Given this list of marker genes Trim11, Ephb1, Tgfb1i1, Msx2, Stat5b, Eid2b, Acvrl1, Mfn2, Lilrb4b, Nr2e1, Sox10, Fgf9, S1pr3, Id1, Hoxa9, Ldb1 (LIM domain binding 1), Nmrk2, Lilrb4a, Cdc73, Plxna3, Mir133a-1, Foxa2, Cxcl14, Clec4g, Thy1 (thymus cell antigen 1, theta), Wnt4, Trpv1, Mir125a, Bmal1, Rap1gap, Runx1, Dpf2, Tgfb2, Mir669a-4, Hey1, Zbtb7b, Prmt5, Npr2, Nodal, Gdf11, Elf5, Vhl, Clec2i, Cdkn2a, Xbp1 (NCBI Gene Id 52219), Tbx1, Shh, Meis2, Disp3 (NCBI Gene Id 631463), Notch1, Slc6a4, Grem1, Casz1, Bcl7a, Six4, Trib1, Kdm1a, Rgs4, Ankrd26 (ankyrin repeat domain 26), Pglyrp2, Rest, Extl3, Asxl1, Pbx1, Myc, Il4, Mafb, Il17rd, Kifap3, Ntn1, Trio, Igf1, Ankrd2 (NCBI Gene Id 56642), Efnb3, Map2, Nkx3-2, Fgfr1, Pcid2, Axin1, Pramel1, Kat8, Flt3, Rc3h1, Ccnk, Six3, Med28, Ifrd1, Fas, Mir23a (microRNA 23a), Ihh, Mir30c-2, Fezf2, Lag3, Ntrk3, Trim72, Trpc5, Stat3, Fndc3b, Foxg1, Trak2, Bmp2, Abcc8, Sinhcaf, Nf2 (neurofibromin 2), Ptprs, Nox1, Shb, Inpp5d, Men1, Tgfb1, Zc3h12a, Tmem178, Gorasp1, Pira12, E2f1, Notch3, Ccn4, Fstl4, Rtn4r, Hoxb8, Sfrp1, Gdf5, Cit, Trim46, Clec2g, Ptk2, Mbnl3 (muscleblind like splicing factor 3), Ezh2, Smad3, Fbxw7, Pias3, Ulk2, Sema4f, Calr, Skic8, Trp53inp1, Nfatc4, Rbm10, Ccdc85b, Zfp35, Erbb2, Gpr55, Vegfa, Vasn, Paf1, Tunar, Zfp36l2, Dll1, Ccl3, Mir669a-9 (NCBI Gene Id 100526491), Eif4enif1, Ctdp1, Rara, Smad1, Bdnf, Il17d, Rgma, Dact3, Fstl3, Ctr9, Adcyap1, Cdk12, Epha7, Dmd, Hbp1, Nr1d1, Hspa9, Wnt7a, Bmp4, Foxp1, Foxj2, Ptch1, Mir669a-10, Tmem64, Rufy3, Nfkbia, Nme1, Smad6, Pax6, Daxx, Nbn, Hook3, Cd44, Dicer1, Ucma, Zfp36, Tspo, Pawr, Reg3a, Erfe, Spart, Fgf13, Cfl1, Ppara, Pira1, Notch4, Foxp4, Spdef, Lbx1, Rbm15, Nfatc2, Sema3g, Mir669a-1, Pik3r1, Tnn, Ptk2b, Igf2 (insulin-like growth factor 2), Gpr171, Yy1, Actl6b, Spred3, Cdkl3, Frs2, Hopx, Adipor1, Noct, Il2, Sox3, Mmp11, Spred2, Snai1, Insig1, Cntf (NCBI Gene Id 12803), Itgav, Ulk1, Appl2, App, Wnt3a, Pou4f2, Trpm4, Slc4a2, Ccl21b, Flcn, Tcf7l2, Rflnb, Mir7-1, Foxa1, Pparg, Suz12, Daam2, Id4, D130043K22Rik, Klf13, Nfatc1, Dtx1, Ctnna1, Kdm4a, Dlk1, Eif2ak4, Rtn4, Nepro, Tcf15, Sox8, Irf1, Lsm1, Nppc (natriuretic peptide type C), Tnfaip6, Prl2c2, Rnf6, Lbh, Tmem131l, Lrp4, Lrrc17, Smarcd1, Kras, Mir217, Tmem176a, Ccn3, Ldlr, Ipo7, Runx1t1, Foxp3, Sall1, Zfp750, Smad4, Chadl, Pcm1, Gper1, Fbn1, Ryk, Tmem53 (transmembrane protein 53), Pi16, Sema3f, Esrrb, Lhx2, Smarcc1, Mkx, Dleu2, Ldlrad4, Zfhx3 (NCBI Gene Id 68160), Trp53, Meis1, Hey2, Ranbp3l, Rbpj, Ceacam1, Tmem182, Vegfc, Ubash3b, Mir338, Fbxo11, Col5a1, Tnpo2, Hnrnpu, Bbs12, Ccl11, Socs1, Dnmt1, Rpl3l, Gfi1 (growth factor independent 1 transcription repressor), Wnt9a, Lmx1a, Draxin, Ifnb1, Apcs, Vsx2, Spry2, Phox2b, Bex1, Sirt2, Nkx2-1, Zfpm1, Cdk13, Sort1, Itgb3, Sorl1, Wnt1, Sostdc1, B2m, Gdi1, Sox21, Twist2, Trim6, Srsf6, Btg2, Adamts7, Hes5, Mir30c-1, Sox4, Zfp36l1, Fuz, Bcl6 (NCBI Gene Id 12053), Bicral, Prdm16, Shoc2, Six2, Irgm1, Glis1, Bambi, Slc7a10, Bmpr1a, Tmem98, Clec2d (NCBI Gene Id 93694), Dlx2, Pth, Tlx3, Rorb, Wnt3, Anxa1, Slit2, Tmem176b, Oog2, Arhgap4, Il1b, Msx1, Gsk3a, Wnt5a, Rgs2, Mir137, Atf5, Tsc22d1, Gpr137, Actb, Foxo3, Cul4a, Nrp1, Adgrv1, C1qc, Tnf, Mbp, Akirin1, Tsc2, Ddx6, Rbpms2, Pkp2, Lingo1, Axin2, Spsb3, Rhoa, Dip2b, Fgfr3, Sox9, Stat1 (signal transducer and activator of transcription 1), Mir669a-2, Mir448, Plpp7, Cftr, Foxo4, Mixl1, Ncor2, Hmga2, Tcf23, Cav3, Hoxa5, F2, Fgf23, Nog, Ostn, Cib1, Hes1, Wnt7b, Tomm70a (NCBI Gene Id 70049), Fbxo7, Spinkl, Nf1, Areg, Cd74, Sox11, Ccr5, Ereg, Ascl2, Ybx1, Arhgef2, Nkx6-2, Nfatc3, Mycn, Ankrd17 (NCBI Gene Id 81702), Ahr, Mir669a-8, Ccnd1, Nrarp, Foxe3, Id2, Sema6d (sema domain, transmembrane domain (TM), and cytoplasmic domain, (semaphorin) 6D), Skil, Eif4e, Thoc5, Prdx2, Cdh1, Cav1, Tlx2, Mir669a-3, Bmpr2, Sema5a, Nbr1, Ephb2, Pinc, Snai2, Mir669a-5, Wee2, Zbtb46, Aspm, Smo, Hmgb3, Usf3, Itpkb, Efemp1, Gps2, Crp, Vax1, Mapk1, Fgl2, Gabpa, Wwtr1, Cartpt (CART prepropeptide), Mib1, Gli3, Itgb1, Dpysl5, Hpn (hepsin), Dab1, Fmr1, Loxl3, Cers2, Hspb1, Dll3, Socs5, Bcl7b, Dkk1, Ss18, Riox1, Olig2, Zhx2, Pak1, Yap1, Tjp2, Sirt1, Grb14, Chrd, Dab2ip, Gli2, Sema4d, Pglyrp1, Ltbp3, Cntn4, Rag2, Bicra, Tlcd3b, Actr3 (ARP3 actin-related protein 3), Zfp418, Zfpm2, Cbfb, Kctd11, Cited1, Ptpn11, Prox1, Cdk5rap2, Sema6c, Ifng, Nkx2-2, Adipoq, Hoxa7, Col5a2, Il4ra, Sod2, Anp32b, Rarg, Ctla4, Trpv4, Isl1, Iqcb1, C1ql4, Ctdsp1, Tert, Rcan1, Tgfbr3, Hdac5, Mark1, P2ry12, Ppp3ca (protein phosphatase 3, catalytic subunit, alpha isoform), Pglyrp3, Tgfbr1, Myb (myeloblastosis oncogene), Fuom, Pou5f1, Nkx6-1, Jak3, Rb1, Fst, Epha4, Med1, Nfkbid, Cysltr2, Nkx2-5, N4bp2l2, H2-M3, Osr1, Iapp, G6pd2, Trib3, Xdh, Tcta, Cldn18, Cxcl10, Pten, Hdac3, Wnt10b, Zc3h8, Lrp6, Idh2, Mbd1, Dusp10, Csrp3, Mir154, Cd69, Jdp2, Ltf, Pdgfb, Ccl9, Smad7, Oog1, Tnr, Ptger3, Ptpn2 (NCBI Gene Id 19255), Slit1, Nucb2, Tbx21, Ednrb (NCBI Gene Id 13618), Sema3a, Sox2, Zbed6, Trem2, Crim1, Actl6a, Hdac7, Fermt2, Sdhaf2, Oog3, Cebpa, Sra1, Mag, Tent5c (terminal nucleotidyltransferase 5C), Mir135a-1, Gdf3, Ddit3, Brinp1, Ypel4, Il1a, Mir205, Pilrb1, Mir669a-7, Tbx6, Lmo2, Tmem119, Psen1, Efna1, Ythdf2, Nkx6-3, Cd24a, Prmt1, Dixdc1, Abcg1, Ascl1 (NCBI Gene Id 17172), Leo1, Pramel7, G6pdx, Nphp3, Ptn, Trpc6, Frzb (frizzled-related protein), Ctnnb1, Prickle1, Brd9, Hlx, Il18, Mettl14, Hoxa2, Mt3, Fzd7, Hdac4, Mad2l2, Mir214, Rnf10, Abca5, Nfe2l2, Prtg, Ncoa3, Bhlha15, Trp63, Mmp9, Ttpa, Foxo1, Sox6, Tob1, Mdk, Nme2, Enpp1, Pdcd4, Dlx1, Ppard, Syngap1, Cdk6, Smarca4, Tob2, Atoh1, Twist1, Myocd, Prdm6, Bcl11a, Runx3, Rora, Zeb1, Ush2a, Spag9, Twsg1, Apbb1, Mir133a-2, Rflna, Hmg20a (NCBI Gene Id 75713), Syt4, Trib2, Ywhah, Trim62, Hdac6, Pitx3, Trp73, Mir204, Qki, Ski, Pglyrp4 (NCBI Gene Id 384997), Stat5a, Rc3h2, Gpr68, Tnfrsf11b, Ttc3 (NCBI Gene Id 70444), Mstn, Hdac8, Mir133b, Foxj1, Tsku, Bmyc, Lrp5, Ovol2, Zfp608, Gata2 (NCBI Gene Id 14461), Lgals1, Rarb, Spry1, Nelfb, Tmsb4x, Lrp3, Dnajb11, Tbx3, Lin28a, Smarca2, Drd3, Dynlt1b, Mir669a-6, S100b, Jag1, Id3, Clec12a, Sfrp2, Cntn2, Bmp7, Nanog, Zfp932, Reg3g, Ppp2ca, Pthlh, Mecp2, Bcl7c, Hand2, Limd1, Isl2, Fgf10, Inpp4b, Lyn, Gpr37l1, Cdk5, Bhlhe41, Ptgr3, Igfbp5, Hmgb1, Pf4, Cdkn2b (NCBI Gene Id 12579), Adamts12, Irx3, Zfp536, Dsg2, Egfr, Tnfsf18, Rapgef2, Csf1r, Il36g, Gata3, Gpr137b, Cmtm5, Spred1, Mesp1, Ccnd2, Gsk3b, Nr5a2, Ptbp1, Ccl17, Tnfsf4, here is a description of the gene set: Any process that stops, prevents, or reduces the frequency, rate or extent of cell differentiation. Mouse Gene Set: GOBP_NEGATIVE_REGULATION_OF_CELL_DIFFERENTIATION species: Mus musculus